Given this list of marker genes HSPB1, FRYL, ALDH1A2, PSME1, TTLL3, TCP10L3, SLC14A1, SLC17A7, MEOX1, RELA, ITGB3, CAMTA1, ZHX2, KRT85, DUSP5, LYPD3 (LY6/PLAUR domain containing 3), SLC39A8, SYMPK (symplekin scaffold protein), TNFAIP6, ATP6V0A2, PRPF3, CGREF1, MIF, FCN3, NFIB (nuclear factor I B), ETS2, IL1RN (NCBI Gene Id 3557), BATF, TIMP1, ADM, MARCHF2, PSME2, GADD45A, STAG2, CCR7, ATP12A, H2AC6, HSD11B1, CXCR4, LITAF, DENND3, HLA-DOB, IER3, SERPINA4, PTPN1, CHD2, KRT86, PPARG, SGPL1, MAGEA4, TNF, BTG1, PADI2, RAB29, TRPM1, WDR13, RHOQ, APBA3, ADAM19, RAB8A, KDM6B, IFITM3, GPX2, DNTTIP2, TYMP, ABO, KDM7A, CTSL, S1PR4, NAMPT, TFE3, ITGAV, RTL8C, MTSS2, AUH (NCBI Gene Id 549), SERPINA1, SLPI, CDX1, MARCKSL1, IGHMBP2, LGALS4, ELAVL2, EZH2, ENO2, ZNF785, PCDHA9, RGS1, AHR, SIRPB1, FOXF1, NDRG2, CPNE6, SPHK2, CELF2, THPO, TAF6L, TDRD7, SOX9, PIM1, CABP1, PITX2, RNF19B, AVIL, TNFAIP3, CASC3, PHLDA2, MT1G, RGL1, VAMP5, SOCS2, IFI6, CRYAB, ELL2, FCGR2B, IFNGR2, SECTM1, SLC25A16, BMP1, VAC14, MT2A, KLF6, G0S2, GPR15, IDO1, ITSN2, RGS12, PSMB9, ZNF253, SERPINB9, MEF2D, RRAGA, P2RX5, DLGAP1, IL23A, IL10, IRF1, VPS13A, PARD6B, ATP1B3, ID2, LAMB1, TPO, UCP2, KYNU, RRAGD, DNAH7 (NCBI Gene Id 56171), POU3F2, SMNDC1 (survival motor neuron domain containing 1), SFTPC, SOD2, CIC, UBE2L6, THBD, PTGER2, SALL2, TJP2, CCL2, MMP9, TAP1, CYP3A5 (cytochrome P450 family 3 subfamily A member 5), CETN2, CD40, IRS2, ARL4A, CTF1, EVPL, FLT3LG, GAL, ACOX1, DDIT4, MPZ, CDK17, GMPR, CD5, DPF2, H1-10, ATP8B1, PLS3, PAX3, TRIB1, ZMYND10, FBLN5, PEBP1, POU2F2, CXCL8, SMURF2, ATP6V0C (NCBI Gene Id 527, ATPase H+ transporting V0 subunit c), HGFAC, MAG, IFI35, ADPRH, OCRL, TRIM66, GAB1, S100A10, CCR6, ATP2C1, LLGL2, CFLAR, here is a description of the gene set: species: Homo sapiens from publication Chaussabel D, Semnani RT, McDowell MA, Sacks D, Sher A, Nutman TB (PMID 12663451) Monocyte-derived dendritic cells (DC) and macrophages (MΦ) generated in vitro from the same individual blood donors were exposed to five different pathogens, and gene expression profiles were assessed by microarray analysis. Responses to Mycobacterium tuberculosis and to phylogenetically distinct protozoan (Leishmania major, L. donovani, Toxoplasma gondii) and helminth (Brugia malayi) parasites were examined, each of which produces chronic infections in humans yet vary considerably in the nature of the immune responses they trigger. Genes down-regulated in untreated dendritic cells (DC) versus DCs exposed to parasite L. major. Human Gene Set: GSE360_CTRL_VS_L_MAJOR_DC_DN